Given this list of marker genes CR2, IGKV3-20, IGLC2, C7, C3, C2, CFHR1, CFP, IGKV1-5, C5AR1, IGHG1, COLEC11, N, IGKV2-28, IGKV4-1 (NCBI Gene Id 28908), IGHG2, VTN, C1QC, IGKV5-2, IGKV2-30, COLEC10, IGKV1D-16, FCN1 (ficolin 1), CFHR5, C3AR1, CR1, IGHV2-70, M, IGKV1D-33, C8B, CPN2, IGHV2-5, SERPING1, IGLV7-43, PROS1, C1S, F2, C1QB, IGHV3-9, MASP2, IGHV1-46 (NCBI Gene Id 28465), IGLV2-8, CFI, IGKC, FCN3, IGKV1-33, IGLC1, C8G, CLU, IGLV4-60, IGHG3, IGHV4-34, 7a, CFHR4, IGHV3-11, IGHV3-53, CPN1, IGKV3D-20, IGLV2-11 (NCBI Gene Id 28816), E, IGLV4-3, CFHR3, IGLV, IGHV, IGLV6-57, CFH, C4BPA, IGLV1-51, IGLC3, IGLV2-14, IGKV1D-12, IGKV1-17, MASP1, C5AR2, IGLV2-23, CRP, IGLV3-27, C5, IGKV2D-30, IGHV4-59, IGLV1-36, IGLV3-25, IGLV1-47, CD81, IGKV1-39, CD59, IGHV1-69, IGKV1-12, CD55, IGHV3-7 (NCBI Gene Id 28452), IGHV3-33, CFB, IGHV4-39, CD46, IGKV1-16, C4A, IGLV2-18 (NCBI Gene Id 28814), IGLV1-40, IGLV7-46, C6, GZMM, IGHV3-23, C4B, IGKV2-29, IGHV3-13, IGLV3-12, IGLV3-16, IGLV4-69, CFHR2, IGLV5-45, SARS coronavirus, complete genome, IGHV7-81, IGLV3-22, IGLC7, ELANE, C4BPB, IGLV11-55 (immunoglobulin lambda variable 11-55 (non-functional)), IGKV2D-28, C9, IGLV2-33, IGLV3-19, MBL2, CPB2, IGKV3-15, IGKV1D-39, IGLV5-37, CD19, FCN2, IGLV8-61, CFD, IGLV3-1 (immunoglobulin lambda variable 3-1), C1QA, IGHV3-48, IGLV3-21, S, C1R, IGLC6, IGKV3-11, 3a, IGLV10-54, IGLV1-44, IGHG4, IGHV3-30, IGKV2D-40, IGHV1-2, C8A, here is a description of the gene set: Reactome Pathway: Complement cascade species: Homo sapiens part of: Innate Immune System In the complement cascade, a panel of soluble molecules rapidly and effectively senses a danger or damage and triggers reactions to provide a response that discriminates among foreign intruders, cellular debris, healthy and altered host cells (Ricklin D et al. 2010). Complement proteins circulate in the blood stream in functionally inactive states. When triggered the complement cascade generates enzymatically active molecules (such as C3/C5 convertases) and biological effectors: opsonins (C3b, C3d and C4b), anaphylatoxins (C3a and C5a), and C5b, which initiates assembly of the lytic membrane attack complex (MAC). Three branches lead to complement activation: the classical, lectin and alternative pathways (Kang YH et al. 2009; Ricklin D et al. 2010). The classical pathway is initiated by C1 complex binding to immune complexes, pentraxins or other targets such as apoptotic cells leading to cleavage of C4 and C2 components and formation of the classical C3 convertase, C4bC2a. The lectin pathway is activated by binding of mannan-binding lectin (MBL) to repetitive carbohydrate residues, or by binding of ficolins to carbohydrate or acetylated groups on target surfaces. MBL and ficolins interact with MBL-associated serine proteases (MASP) leading to cleavage of C4 and C2 and formation of the classical C3 convertase, C4bC2a. The alternative pathway is spontaneously activated by the hydrolysis of the internal thioester group of C3 to give C3(H2O). Alternative pathway activation involves interaction of C3(H2O) and/or previously generated C3b with factor B, which is cleaved by factor D to generate the alternative C3 convertases C3(H2O)Bb and/or C3bBb. All three pathways merge at the proteolytic cleavage of component C3 by C3 convertases to form opsonin C3b and anaphylatoxin C3a. C3b covalently binds to glycoproteins scattered across the target cell surface. This is followed by an amplification reaction that generates additional C3 convertases and deposits more C3b at the local site. C3b can also bind to C3 convertases switching them to C5 convertases, which mediate C5 cleavage leading to MAC formation. Thus, the activation of the complement system leads to several important outcomes: opsonization of target cells to enhance phagocytosis, lysis of target cells via membrane attack complex (MAC) assembly on the cell surface, production of anaphylatoxins C3a/C5a involved in the host inflammatory response, C5a-mediated leukocyte chemotaxis, and clearance of antibody-antigen complexes. The complement system is able to distinguish between pathological and physiological challenges, i.e. the outcomes of complement activation are predetermined by the trigger and are tightly tuned by a combination of initiation events with several regulatory mechanisms. These regulatory mechanisms use soluble (e.g., C4BP, CFI and CFH) and membrane-bound regulators (e.g., CR1, CD46(MCP), CD55(DAF) and CD59) and are coordinated by complement receptors such as CR1, CR2, etc. In response to microbial infection complement activation results in flagging microorganisms with opsonins for facilitated phagocytosis, formation of MAC on cells such as Gram-negative bacteria leading to cell lysis, and release of C3a and C5a to stimulate downstream immune responses and to attract leukocytes. Most pathogens can be eliminated by these complement-mediated host responses, though some pathogenic microorganisms have developed ways of avoiding complement recognition or blocking host complement attack resulting in greater virulence (Lambris JD et al. 2008; Serruto D et al. 2010). All three complement pathways (classical, lectin and alternative) have been implicated in clearance of dying cells (Mevorach D et al. 1998; Ogden CA et al. 2001; Gullstrand B et al.2009; Kemper C et al. 2008). Altered surfaces of apoptotic cells are recognized by complement proteins leading to opsonization and subsequent phagocytosis. In contrast to pathogens, apoptotic cells are believed to induce only a limited complement activation by allowing opsonization of altered surfaces but restricting the terminal pathway of MAC formation (Gershov D et al. 2000; Braunschweig A and Jozsi M 2011). Thus, opsonization facilitates clearance of dying cells and cell debris without triggering danger signals and further inflammatory responses (Fraser DA et al. 2007, 2009; Benoit ME et al. 2012). C1q-mediated complement activation by apoptotic cells has been shown in a variety of human cells: keratinocytes, human umbilical vein endothelial cells (HUVEC), Jurkat T lymphoblastoid cells, lung adenocarcinoma cells (Korb LC and Ahearn JM 1997; Mold C and Morris CA 2001; Navratil JS et al. 2001; Nauta AJ et al. 2004). In addition to C1q the opsonization of apoptotic Jurkat T cells with MBL also facilitated clearance of these cells by both dendritic cells (DC) and macrophages (Nauta AJ et al. 2004). Also C3b, iC3b and C4b deposition on apoptotic cells as a consequence of activation of the complement cascade may promote complement-mediated phagocytosis. C1q, MBL and cleavage fragments of C3/C4 can bind to several receptors expressed on macrophages (e.g. cC1qR (calreticulin), CR1, CR3, CR4) suggesting a potential clearance mechanism through this interaction (Mevorach D et al. 1998; Ogden CA et al. 2001). Apoptosis is also associated with an altered expression of complement regulators on the surface of apoptotic cells. CD46 (MCP) bound to the plasma membrane of a healthy cell protects it from complement-mediated attack by preventing deposition of C3b and C4b, and reduced expression of CD46 on dying cells may lead to enhanced opsonization (Elward K et al. 2005). Upregulation of CD55 (DAF) and CD59 on apoptotic cell surfaces may protect damaged cells against complement mediated lysis (Pedersen ED et al. 2007; Iborra A et al. 2003; Hensel F et al. 2001). In addition, fluid-phase complement regulators such as C4BP, CFH may also inhibit lysis of apoptotic cells by limiting complement activation (Trouw LA et al 2007; Braunschweig A and Jozsi M. 2011). Complement facilitates the clearance of immune complexes (IC) from the circulation (Chevalier J and Kazatchkine MD 1989; Nielsen CH et al. 1997). Erythrocytes bear clusters of complement receptor 1 (CR1 or CD35), which serves as an immune adherence receptor for C3 and/or C4 fragments deposited on IC that are shuttled to liver and spleen, where IC are transferred and processed by tissue macrophages through an Fc receptor-mediated process. Complement proteins are always present in the blood and a small percentage spontaneously activate. Inappropriate activation leads to host cell damage, so on healthy human cells any complement activation or amplification is strictly regulated by surface-bound regulators that accelerate decay of the convertases (CR1, CD55), act as a cofactor for the factor I (CFI)-mediated degradation of C3b and C4b (CR1, CD46), or prevent the formation of MAC (CD59). Soluble regulators such as C4BP, CFH and FHL1 recognize self surface pattern-like glycosaminoglycans and further impair activation. Complement components interact with other biological systems. Upon microbial infection complement acts in cooperation with Toll-like receptors (TLRs) to amplify innate host defense. Anaphylatoxin C5a binds C5a receptor (C5aR) resulting in a synergistic enhancement of the TLR and C5aR-mediated proinflammatory cytokine response to infection. This interplay is negatively modulated by co-ligation of TLR and the second C5a receptor, C5L2, suggesting the existence of complex immunomodulatory interactions (Kohl J 2006; Hajishengallis G and Lambris JD 2010). In addition to C5aR and C5L2, complement receptor 3 (CR3) facilitates TLR2 or TLR4 signaling pathways by promoting a recruitment of their sorting adaptor TIRAP (MAL) to the receptor complex (van Bruggen R et al. 2007; Kagan JC and Medzhitov R 2006). Complement may activate platelets or facilitate biochemical and morphological changes in the endothelium potentiating coagulation and contributing to homeostasis in response to injury (Oikonomopoulou K et al. 2012). The interplay of complement and coagulation also involves cleavage of C3 and C5 convertases by coagulation proteases, generating biologically active anaphylatoxins (Amara U et al. 2010). Complement is believed to link the innate response to both humoral and cell-mediated immunity (Toapanta FR and Ross TM 2006; Mongini PK et al. 1997). The majority of published data is based on experiments using mouse as a model organism. Further characterization of the influence of complement on B or T cell activation is required for the human system, since differences between murine models and the human system are not yet fully determined. Complement is also involved in regulation of mobilization and homing of hematopoietic stem/progenitor cells (HSPCs) from bone marrow to the circulation and peripheral tissue in order to accommodate blood cell replenishment (Reca R et al. 2006). Thus, the complement system orchestrates the host defense by sensing a danger signal and transmitting it into specific cellular responses while extensively communicating with associated biological pathways ranging from immunity and inflammation to homeostasis and development. Originally the larger fragment of Complement Factor 2 (C2) was designated C2a. However, complement scientists decided that the smaller of all C fragments should be designated with an 'a', the larger with a 'b', changing the nomenclature for C2. Recent literature may use the updated nomenclature and refer to the larger C2 fragment as C2b, and refer to the classical C3 convertase as C4bC2b. The complement cascade pathway is organised into the following sections: initial triggering, activation of C3 and C5, terminal pathway and regulation.